Given this list of marker genes Selp, Add2, Itga4, Rela, Cxcl12, Rock1 (NCBI Gene Id 68785), Fut4, Nfat5, Jam2, Vcam1, Zdhhc21, Gp1ba, Lrg1, Ccl21e, Fut9 (fucosyltransferase 9), Elane, St3gal4, Ccl28 (C-C motif chemokine ligand 28), Ccr2, Slc39a8, Tnf, Ets1, Klf4, Mdk, Cx3cr1, Il6, Ext1, Ptafr, Chst2, Capn1, Icam1, Ccl21d, Sell, Chst4, Itgam, Spn, Pawr, Itgb1, Sele, Podxl2, Gcnt1, Irak1, Traf6, Lep, Itgb7, Fut7, Golph3, Ccl25, Madcam1 (NCBI Gene Id 17123), Alox5, Rhoa (NCBI Gene Id 51787), Itgb2, Ccl21a, Ccl21b (C-C motif chemokine ligand 21B (leucine)), Ccl21f, Selplg, here is a description of the gene set: Mouse Gene Set: GOBP_LEUKOCYTE_ADHESION_TO_VASCULAR_ENDOTHELIAL_CELL The attachment of a leukocyte to vascular endothelial cell via adhesion molecules. species: Mus musculus